The following is a description of a gene set: Monocyte-derived dendritic cells (DC) and macrophages (MΦ) generated in vitro from the same individual blood donors were exposed to five different pathogens, and gene expression profiles were assessed by microarray analysis. Responses to Mycobacterium tuberculosis and to phylogenetically distinct protozoan (Leishmania major, L. donovani, Toxoplasma gondii) and helminth (Brugia malayi) parasites were examined, each of which produces chronic infections in humans yet vary considerably in the nature of the immune responses they trigger. studied in species Homo sapiens from publication Chaussabel D, Semnani RT, McDowell MA, Sacks D, Sher A, Nutman TB (PMID 12663451) Human Gene Set: GSE360_DC_VS_MAC_B_MALAYI_LOW_DOSE_DN Genes down-regulated in comparison of dendritic cells (DC) exposed to 5 worm/well B. malayi versus macrophages exposed to 5 worms/well B. malayi., and this is the list of marker genes: GREM1, MADD, SLC25A1, PDE8A, ATXN2L, H2BC12, SUSD5, SRD5A1, MSC, TCOF1, FANCL, USP12 (NCBI Gene Id 219333), MAPK9, ALK, HERC2P3, ITSN1 (intersectin 1), TICAM1, MTMR1, LPL, OXA1L, STAT4, MT1B, CHD3, FAM50B (NCBI Gene Id 26240), COPS7A, OAS2, DHCR24, EIF1AX (eukaryotic translation initiation factor 1A X-linked), FGR, TRIP6, MARF1, EMP3, MAGED1, SPAG7, PBX2, PSMD8, SPIDR, WAS, PLP2, HDLBP, MYD88 (MYD88 innate immune signal transduction adaptor), MAP3K12, RBCK1, PPP1R15A (NCBI Gene Id 23645), MRPS18B, ENOSF1, GPR65, BTN3A1, BST2, TNFRSF10B, RSBN1, DNAJC11, ERCC3, IFIT5, ZBTB24, SDC1, VPS11, AGPAT2, ATG14, HDDC2, SIAH1 (siah E3 ubiquitin protein ligase 1), RFX2, MIF, FAM131B (family with sequence similarity 131 member B), MYBPC2, FBP2, CD19, HTR1B, PPIE, AMHR2, BABAM2, HSPA5, SLC6A8, CCR7, RELA, ZNF337, PRDX4 (NCBI Gene Id 82852), TRIP10, GLO1, RPP14, POLR2K, ADD1, OCEL1, PMVK, SIVA1, RAB4A, AASS, CEACAM8, SLC25A3, ATP6V1G2, SULF1, SEC31A, SQLE, PWP1, PFKFB4, IDS, POU2F2, TRIM27, NDUFAB1, DDX17, IL2RG, SPP1, CHRND, PLXNC1, G0S2, SERPINE2, CD7, CAPZB (NCBI Gene Id 832), DCTN2, URB2, E2F4, YAF2, SEC61B, ANGPTL7, GPD2, TNP1, PKD1, TRAPPC3, WIPI2, CMKLR1, CDK2AP2, SPINK4 (NCBI Gene Id 27290), BTD, LTBP4, NINJ1, ILVBL, CALML3, ESD, AHSG, LILRA1, ITGA3, ATP6V1H, CNOT3, TOX4, DHX38, MT4, GPNMB, PPP2R5D, MZF1, EEIG1, BRD2, CETN2, CNPY3, SELENOP, S100A9, TMEM131L, MUC6, ZMYM2, CD14, FADS1, B3GNT2, ARR3, WTAP, PABPC4, PARVB, GNG7, PRRG1, PFKL, MNT, WNT2B, STOM, USP7, PSMA4, LHX2, RABAC1, MPI, JTB, SLC31A2 (NCBI Gene Id 1318), PYGM, CLPP, GORASP2, HGS, SIAH2, YIPF1, TOMM40, AKAP17A, KCTD12, INPP5F, PSD, SLC10A3, GNRH2, CAD, HIVEP1, PPP2R5A, RRP7A, PFDN4, MBD3, TIMP2, MYOF, GATM, IDH2 (isocitrate dehydrogenase (NADP(+)) 2), RYR2, TBC1D9, CRYBG3, PIGA, PADI2, GHRH, WDR18, PXDC1, CYB5R1